Given this list of marker genes Trib3, Xdh, Pid1, Mir26a-1, Prkag2, Hnf1a, Bdkrb1, Ppia, Hnf4a, Cdkn1a, Rgn, Gfra2, Arrb1, Hnrnpu, Nnt, Smpd1, Nup62, Socs5, Cadm1, Traf3ip1, Ocln, Pard6a, Ggnbp2, Rps23rg1, Suz12, Gadd45b, Sfrp2, Dgkq, Ccnb1, Irs2, Pdcd4, Adarb1, Gadd45a, Cadm4, Sirt2, Cdkn2c, Ptprb, Lyn, Prkcz, Aida, Lats2, Rack1, Smo, Heg1, Cox11, Gstp1, Tfap4, Pip5kl1, Tsg101, Cep85, Bak1, Gpd1l, Wee2, Sfrp1, Thy1, Rassf2, Cav1, Zc3h12a, Garem1, Eif4g1, Birc3, Gstp-ps, Bdkrb2, Mapt, Akt1, Ptk6, Blvra, Ttc36, Smyd3, Inpp5k, Rasip1, Acp4, Srcin1, Ogt, Pax6, Cdkn2a, Rtraf, Macroh2a1, Hgf, Ceacam1, Prkn, Pparg, Cd109, Spag9, Crkl, Parp14, Ubash3b, Plpp3, Sh3gl2, Gadd45g, Nppa, Prr5l, Kat2b, Ibtk, Cnksr3 (Cnksr family member 3), Lilrb4b, Sh2d1b1, Samsn1, Ctdsp2, Mtor, Pecam1, Lrrk1, Myocd, Wnk4, Prkdc, Pard3, Cdk5rap3, Spry4 (NCBI Gene Id 328944), Ptprc, Ntrk3, C9orf72, Epm2a, Hexim2, Fem1a, Dusp10, Deptor, Cactin, Sh3bp5, Hmgcr, Cav3, Il2, Snca, Gprc5a, Stk38, Hspa4 (heat shock protein 4), Gbp4, Ppp2r5d, Hhex, Insr, Men1, Chp1, Nck1, Lrp6, Pkig, Prkca, Tmed2, Zgpat, Dusp7, Epha1 (Eph receptor A1), Mllt1, Ptprt, Chordc1, Paqr3, Tsc2, Ptprj, Pkn1, Pibf1, Angpt1, Gba1, Dbndd2, Pkia, Agt, Lilrb4a, Tesk1, Jun, Impact, Cdkn1b, Hyal2, Uchl1, Ppp1r15a, Grb10, Dnaja1, Dkk1, Cib1, Ppp4c, Mir26b, Mapk8ip1, Hspb1 (NCBI Gene Id 15507), Nf2, Ager, Abl1, Prkch (NCBI Gene Id 18755), Inpp5f, Spry2, Dmtn, Nolc1, Ctdspl, Bag1, Tigar, Sfrp5, Cdk5rap1, Pbk, Dusp3, Adipoq, Cdkn2d, Dnaja3, Klhl31, Kirrel2, Mstn, Ptpn13, Sirt1, Inpp5j (inositol polyphosphate 5-phosphatase J), Dnajc3, Dynll1, Prkrip1, Akt1s1, Errfi1, Mas1, Gckr, Wars1 (NCBI Gene Id 640248), Nf1, Qars1, Bax, Met, Mlxipl, Irf1, Ptpn6, Ptpn1, Coro1c, Gskip, Niban1, Ajuba, Cdkn1c, 2610042L04Rik, Irak3, Spry1, Dusp22, Dtnbp1, Pkib, Dab2ip, Cd300a, Cblc, Mir26a-2, Dvl1, Bmp2, Rb1, Fkbp8, Zbed3, Enpp1, Tardbp, Taf7, Ptprh, Psen1, Nr2f2, Dusp19, Dusp1, Dusp6, Ppp5c, Itgb1bp1, Nlrp12, Trim27, Plec, Grk2, Zfp418 (NCBI Gene Id 232854), Plk1, Spink1, Hipk3, Rabgef1, Nprl2, Midn, Gnaq, Psen2, Prkcd, Adar, Rgs14, Trib1, Myadm, Igf1, Socs3, Atxn7, Tgfb1, Prkar1a, Fabp4, Apc (APC, WNT signaling pathway regulator), Spred1, Ankle2, Chmp6, Ifng, Shb, Ptpn2, Pycard, Ppef2, Atxn1, Park7, Slfn1, Ppargc1a, Fbxo7, Ptgis, Lats1 (NCBI Gene Id 16798), Ptpro, Prdx3, Terf2ip, Ntf3, Atg14, Casp3, Cdkn2b, Npm1, Il18, Inca1, Drd2, Fbln1, Cep43, Slc8a3, Apoe, Slc8a1, Ppm1e, Mvp, Tnfaip3, Ppm1f, Slit2, Kirrel1, Rgs2, Wwtr1, Ctdsp1, Pten, Il1b, Stap1, Socs1, Socs4, Spred2, Ppp1r15b, Insm1 (insulinoma-associated 1), Smad7, Gstp2, Zfyve28, Ptpn22, Gstp3 (NCBI Gene Id 225884), Vps25, Pebp1, Dnajc10, Igfbp3, here is a description of the gene set: Any process that stops, prevents or decreases the rate of addition of phosphate groups to a molecule. Mouse Gene Set: GOBP_NEGATIVE_REGULATION_OF_PHOSPHORYLATION species: Mus musculus